Given this list of marker genes HLA-DRB5, MT-ATP8, HLA-DRB1, CMC1, KLRC1, here is a description of the gene set: Thirty-eight PBMC samples from 25 patients with IPF and 13 matched controls yielded 149,564 cells that segregated into 23 subpopulations. Classical monocytes were increased in progressive and stable IPF compared to controls (32.1%, 25.2%, 17.9%, respectively, p<0.05). Total lymphocytes were decreased in IPF vs controls, and in progressive vs stable IPF (52.6% vs 62.6%, p=0.035). Tregs were increased in progressive vs stable IPF (1.8% vs 1.1% of all PBMC, p=0.007), although not different than controls, and may be associated with decreased survival (P=0.009 in Kaplan-Meier analysis; P=0.069 after adjusting for age, sex, and baseline FVC). Flow cytometry analysis confirmed this finding in an independent cohort of IPF patients. Fraction of Tregs out of all T cells was also increased in two cohorts of lung scRNA-seq. CCL22 and CCL18, ligands for CCR4 and CCR8 Treg chemotaxis receptors, were increased in IPF. The single-cell atlas of the peripheral immune system in IPF, reveals an outcome-predictive increase in classical monocytes and Tregs, as well as evidence for a lung-blood immune recruitment axis involving CCL7 (for classical monocytes) and CCL18/CCL22 (for Tregs). (From Abstract) from publication Unterman A, Zhao AY, Neumark N, Schupp JC, Ahangari F, Cosme C Jr, Sharma P, Flint J, Stein Y, Ryu C, Ishikawa G, Sumida TS, Gomez JL, Herazo-Maya JD, Dela Cruz CS, Herzog EL, Kaminski N (PMID 38717443) Genes upregulated in NK cells from Idiopathic Pulmonary Fibrosis Patients vs. Controls studied in species Homo sapiens Human Gene Set: UNTERMAN_IPF_VS_CTRL_NK_CELL_UP